Given this list of marker genes NFATC3, NFATC2, FKBP1A, NFATC1, PPP3CB, PPIA, CALM1, PPP3R1, PPP3CA, here is a description of the gene set: Reactome Pathway: Calcineurin activates NFAT species: Homo sapiens Signaling by the B cell receptor and the T cell receptor stimulate transcription by NFAT factors via calcium. Cytosolic calcium from intracellular stores and extracellular sources binds calmodulin and activates the protein phosphatase calcineurin. Activated calcineurin dephosphorylates NFATs in the cytosol, exposing nuclear localization sequences on the NFATs and causing the NFATs to be imported into the nucleus where they regulate transcription of target genes in complexes with other transcription factors such as AP-1 and JUN. Calcineurin in the target of the immunosuppressive drugs cyclosporin A and FK-506. part of: Downstream signaling events of B Cell Receptor (BCR)